Given this list of marker genes SCD, PLAT, UBE2H, AOC3, SLC12A2 (NCBI Gene Id 6558), USE1, RAB3D, ISLR, MNAT1, ATP6V0A1, SARDH, DECR1, NAB2, PTOV1, TP53INP2, SEC23A, STMP1, MAN2A1, IL6ST, RIN2, LAPTM4A, GRINA (NCBI Gene Id 2907), TXNDC16, CTSA, SIRT2 (NCBI Gene Id 22933), RARA, VEGFB, OSBPL1A, ENAH, STX5, OSMR, F2R, MTSS2, MAPRE3, NFIB, NNMT, S100A13, COL4A5, NAGK, SSPN, GLMP, GSTM5, GHR, MT1X, HEBP1, BHLHE40, PCOLCE, KDELR3, CLK1, COL1A2, HLA-B, VKORC1, NDUFV3, MAGED2, TNFRSF11B, WASHC2C, ST13, LAMTOR2, MATN2 (matrilin 2), LIMA1, ANXA6, TCEA3, LGALS9, ZNF32, HMGCS1, CNPY2, RALGDS, GRB10, LMO7, GAS1, CAPN6, NFIX, PDCD4, ST3GAL2, CLN6, ANXA4, PTPRCAP, SLC44A2, PTS, RAB9A, CXCL12, ELAVL2, TXNIP, LUM, SDHC, NME3, CYP4V2, PLTP, SND1, THRA, TCF4, PKD2, KAZALD1, DLK1, ITPR2, NRBP2, VPS28, XPA, CSTF2T, TMEM59, MTARC2, FKBP9, CX3CL1, PTX3, ARSA, OXCT1, MAGED1, MMP14, BPHL, NACC2, SMARCA2, SEL1L, TOM1, DAP, ARF5, LPAR1, IFT81, TMED3, PER1, GGA2 (golgi associated, gamma adaptin ear containing, ARF binding protein 2), LRBA, COL1A1, GSTM3 (NCBI Gene Id 2947), JUND, FOXF1, MT1F, SMAD6, APLP2, DCN, CRYBG1, CSRP1, PTPN13, MCEE, KIFAP3, MNT, RASA4B (RAS p21 protein activator 4B), SPTAN1, EBF1, BRI3, DCAF8, COL5A1, RAB5B, OGN, IDH1, RECK, DTD1, WASHC3, PDGFRA, AMOT, SERPINE2, ACADM, IL11RA, SMOC2, TPP1, MAP1LC3A, CXXC5, SMIM14, HSD17B11, HES6, RCN1, RNASE4, LAMA4, CTNND1, RBMS2, GAA, GNPDA1 (glucosamine-6-phosphate deaminase 1), FKBP10, MEIS1, ID2, PRXL2A, GSTM1, PRRX2, MRC2 (mannose receptor C-type 2), ZSCAN21, IFITM3, AGTR2, RPL22, TWIST1, GLOD4, LOX, TIMP3, TCF7L1 (NCBI Gene Id 83439), LAMB2, NUCB2, HSPA2, PDK4, DNM1, CYP1B1, TSPYL4, TAPBP, SGCB, SQSTM1, DHRS7, AEBP1, MYO10, TMEM45A, DNAJB2, SEC31A, GRN, USP22, MYL12B, ID3, LAMP2, LPIN1, RABAC1, EPRS1, CCDC90B, SESN1, PMP22, MRTFA, PCK2, CNN3, STX4, ALDH1A1, LIPA, ID4, RSRP1, DCTN2, COQ9, SLC1A5, TRAFD1, ATRAID, KLF9, ITM2C, LTBP4, SHC1, ZHX1, FGFR2, MGST3 (microsomal glutathione S-transferase 3), NAGA, CYP51A1, KMT2E, ARHGEF25, NDFIP1, MIEN1, GSN, STAT3, DPP7, ECH1, MAB21L2, DHCR7, ERGIC3, YPEL3, HCFC1R1, PYGB, FZD1 (frizzled class receptor 1), TMEM150A, NPC2, ABLIM1, ADAM23, CASK, ZFP90, SFRP2, PNP, NYNRIN, SLC25A17, CCDC80, VEGFD, PTPRM, TLR6, GALK2, NAXE, TRAPPC12, CD276, AP3S1, COPZ2, EIF2AK3, SNAI2, FIBP, MYORG, NAALAD2, RAB24, CD47, TBL1XR1 (NCBI Gene Id 81612), H3-3A, UGT1A10, NDUFA6, PDGFRB, ACTB, SSBP2, CYB5A, IGSF10, SEMA3F, ATP6V1A, MARCKS, CHMP2A, FN1, SSBP4, PTEN, CD24, THBS2, MAOA, CASP9, RRAS, CTDSP2, SERPINB9, CDK14, VDR, ATP6V0D1, SEC22B, SIX1, PPP3CA, PLCD1, CELF2, LAMA2 (NCBI Gene Id 3908), MEIS3, MPC2, IFT25, AKAP12, TMEM205, GNS, GNAI2, RTRAF, MVD (NCBI Gene Id 4597), FKBP7, CSRP2, EID1, EBF3, TM7SF3, COL6A3, EMB, PLA2G7, EN1 (engrailed homeobox 1), RAB11A, IFT70B, PRNP, CDO1, DDIT3, MAP1LC3B, SPTBN1, CACNA1G, GAS6, SLC38A2, TRIO, CPQ, P2RX4, PSAP, LSS, ANK3, GSTZ1, XDH, CPT1A, OGA, SNAPIN, ATN1, MGP, FSCN1, WLS, LXN, SIX4, CACNA1A, TLE5, IL17RA, RRAGC, POU6F1, GAMT, TTC3, TBX15, FAM8A1, MEG3, WDR6, VPS41, ST3GAL5, LRP6, FGFR1, IFI27, COL6A2, SYNPO, POSTN, NDRG3, GABARAP, CAV1, MROH1, PLD3, LYRM2, ITM2B, NPR3, ATG12, NTPCR, CALML4 (calmodulin like 4), SCP2, MXD4, ATF5, GPC4, GAS2, ASCC1 (NCBI Gene Id 51008), PHYH, C1R, SPARCL1, GBA1, ARFGAP3, PIAS3, CCNG2, DKK3, MKRN1, CLTA, MYO1D, PIK3R1, PLPP3, here is a description of the gene set: from publication Berenjeno IM, Núñez F, Bustelo XR (PMID 17213802) We have used microarray technology to identify the transcriptional targets of Rho subfamily guanosine 5'-triphosphate (GTP)ases in NIH3T3 cells. This analysis indicated that murine fibroblasts transformed by these proteins show similar transcriptomal profiles. Functional annotation of the regulated genes indicate that Rho subfamily GTPases target a wide spectrum of functions, although loci encoding proteins linked to proliferation and DNA synthesis/transcription are upregulated preferentially. Rho proteins promote four main networks of interacting proteins nucleated around E2F, c-Jun, c-Myc and p53. Of those, E2F, c-Jun and c-Myc are essential for the maintenance of cell transformation. Inhibition of Rock, one of the main Rho GTPase targets, leads to small changes in the transcriptome of Rho-transformed cells. Rock inhibition decreases c-myc gene expression without affecting the E2F and c-Jun pathways. Loss-of-function studies demonstrate that c-Myc is important for the blockage of cell-contact inhibition rather than for promoting the proliferation of Rho-transformed cells. However, c-Myc overexpression does not bypass the inhibition of cell transformation induced by Rock blockage, indicating that c-Myc is essential, but not sufficient, for Rock-dependent transformation. These results reveal the complexity of the genetic program orchestrated by the Rho subfamily and pinpoint protein networks that mediate different aspects of the malignant phenotype of Rho-transformed cells. Human Gene Set: BERENJENO_TRANSFORMED_BY_RHOA_DN species: Mus musculus Genes down-regulated in NIH3T3 cells (fibroblasts) transformed by expression of contitutively active (Q63L) form of RHOA off plasmid vector.